The following is a description of a gene set: Any recombinational process that contributes to the maintenance of proper telomeric length. species: Mus musculus Mouse Gene Set: GOBP_TELOMERE_MAINTENANCE_VIA_RECOMBINATION, and this is the list of marker genes: Ercc4, Rad51d, Tert, Rad51c, Rad51, Rad50, Xrcc4, Nsmce2, Xrcc3, Tep1, Smc5, Terf2, Ercc1, Smc6, Xrcc1, Brca2